The following is a description of a gene set: Any process that activates or increases the frequency, rate, or extent of integrin activation. Mouse Gene Set: GOBP_POSITIVE_REGULATION_OF_INTEGRIN_ACTIVATION studied in species Mus musculus, and this is the list of marker genes: Plek, Rap1b, P2ry12, Cd24a, Cxcl13, Foxc2, Pcsk5, Cdh17, Skap1, Piezo1, Fermt2 (NCBI Gene Id 218952), Fermt1, Rasip1